Given this list of marker genes IFT140 (intraflagellar transport 140), FIG4, NSDHL, BMPR1B, TBX5, here is a description of the gene set: Absent 2nd (index) finger. Aplasia of the 2nd finger Human Gene Set: HP_APLASIA_OF_THE_2ND_FINGER species: Homo sapiens